The following is a description of a gene set: Genes up-regulated in bone marrow-derived macrophages treated with rosiglitazone: wildtype versus STAT6 knockout. C57Bl/6 wild-type and STAT6 KO mice were used to study PPARg and IL-4 signaling. Bone marrow of 3 mice per group was isolated and differentiated to macrophages with M-CSF (20 ng/ml). 20 ng/ml IL-4 was used to induce alternative macrophage activation and 1 uM Rosiglitazone (RSG) was used to activate PPARg. From each mouse 4 samples were generated: 1. M-CSF, 2. M-CSF+RSG, 3. IL-4 and 4. IL-4+RSG. All compounds were added throughout the whole differentiation process, and frech media was added every other day. Control cells were treated with vehicle (DMSO:ethanol). After 10 days, RNA was isolated and gene expression profiles were analyzed using Mouse Genome 430 2.0 microarrays from Affymetrix. species: Homo sapiens from publication Szanto A, Balint BL, Nagy ZS, Barta E, Dezso B, Pap A, Szeles L, Poliska S, Oros M, Evans RM, Barak Y, Schwabe J, Nagy L (PMID 21093321) Human Gene Set: GSE25088_WT_VS_STAT6_KO_MACROPHAGE_ROSIGLITAZONE_STIM_UP, and this is the list of marker genes: YWHAG, GALNT2, LAPTM4B, TTC3, PPM1F, SLC38A2, HS3ST1, FAM168A, ZBTB44, PEMT (phosphatidylethanolamine N-methyltransferase), RPS6KB2, RPL34, IPO5, FH, CD109, ATP10D, MLEC (NCBI Gene Id 9761), MBTD1, CDC23, TMEM126A, IPO7, ARHGAP35, EDRF1-DT, EEF1A1, TULP4, RNF149, MED23, TUSC2, ARRDC4, NUMB, RANBP2, MRTFB, UFSP2, BABAM1, ZNF704 (zinc finger protein 704), LTB, TMEM245, CCNB1IP1, NUP42, PAPOLA, PLPP5, AKAP9, SOX12, DNAJC4, TMSB15B-AS1, RNF125, IARS2, UQCC3, RDH10, LRAT, TMEM177, SDHD, LCORL, TRMO, GPR155, TLR2, TPP2, NCAPG2, NUTF2, PJA1, ABHD2, ALDOA, BCLAF3, FILIP1L, HLA-DRB4, SLC26A2, ZNF397, TMEM273, ATPSCKMT, FABP4, GAS8-AS1, VEGFB, UCHL3, URB2, VPS13B, NME7, CYTH4, ZNF805, CEP152, EEF2, ZCWPW2, NUDT22, B4GALT3, COX18, TSPO, ST6GAL1, ZMIZ1, TSPYL1, EPHX4, ATXN1, ZNF132, NDUFB8, LYRM7, VGLL4, MID1, GOLGA3, GK5, EIF2AK3, LINC00662, P4HA1, SBNO1, RBPJ, SLC25A3, SEC16A, DPP8, PYROXD2, MIR99AHG, NDUFA3, INPP5A, TRAK2, GAPVD1, MAPK9, UBE2J1, ZCCHC14, RPS3, FNTB, TRIB3, EP400, CAMK1D, SORT1, FRMD4B, SLC25A37, TRDMT1, LAMA4, CEP85L, GTF3A, CLTC, NCAPD2, ZCCHC24, POLR2G, RNF14, DDX39B, FXN, WDR37, ETF1, VPS45, NACA, SRSF1, OSTC (oligosaccharyltransferase complex non-catalytic subunit, NCBI Gene Id 58505), CECR3, RPL21, CHP1, RPF2, DNAAF3, KMT2C, CCDC18, TBC1D2B, LIPT2-AS1, UBXN1, DPCD, HLA-F-AS1, RPS2, RPL13A, PMEPA1 (prostate transmembrane protein, androgen induced 1), ERGIC2, OXA1L, ITGAM, HOMEZ, SPCS3, RPL30, NMT2, UBE2G2, EFR3B, CCDC9B, XRN2, EEF1G, IGIP, RUNX1, PCYOX1, TEX261, ZBTB26, GSAP, SLC45A1, TMEM170B, GUSBP2, PPA2, FBXW7, CTNND1, TSPAN7, ABCD3, COPZ1, CELF1, LINC01278 (long intergenic non-protein coding RNA 1278), RPL8, KRT10-AS1, ZNF280D, AGO2, GPI, GOLGA8H, EPRS1, HCCS, RTN3, ETHE1, SND1-IT1